The following is a description of a gene set: The disaggregation of a ribosome into its constituent components; includes the dissociation of ribosomal subunits. Mouse Gene Set: GOBP_RIBOSOME_DISASSEMBLY studied in species Mus musculus, and this is the list of marker genes: Ankzf1, Cdk5rap3, Mtres1, Saysd1, Gigyf2, Ddrgk1, Zfp598, Rnf14, Elac1, Usp10, Abce1, Mrpl58, Gcn1, Rchy1, Mtif3, Ltn1, Klhdc10, Gtpbp2, Ufsp2, Skic8, Denr, Gfm2, Ascc2, Rack1, Trip4, Pelo, Trnt1, Skic3, Ufl1, Rnf25, Eif4e2, Mcts1, Mtif2, Mrrf, Ptrh1, Ascc3, Nemf, Mtrfr, Tcf25, Skic2, Eif2d, Hbs1l